Given this list of marker genes Hsf1, Esr1, here is a description of the gene set: electronically inferred by orthology from the curated human pathway Reactome Pathway: Mitochondrial unfolded protein response (UPRmt) This event has been computationally inferred from an event that has been demonstrated in another species.<p>The inference is based on the homology mapping from PANTHER. Briefly, reactions for which all involved PhysicalEntities (in input, output and catalyst) have a mapped orthologue/paralogue (for complexes at least 75% of components must have a mapping) are inferred to the other species. part of: Cellular responses to stress species: Mus musculus